The following is a description of a gene set: Any complex of actin, myosin, and accessory proteins. Mouse Gene Set: GOCC_ACTOMYOSIN studied in species Mus musculus, and this is the list of marker genes: Rai14, Xirp2, Pdlim5, Myl9, Micall2, Coro2b, Dixdc1, Ptk2, Sorbs1, Myh14, Kat2b, Fscn1 (NCBI Gene Id 14086), Ablim1, Sh2b2, Myh11, Ptpn11, Pxn, Gas2l2, Fblim1, Gas2l1, Ablim3, Prickle4, Limch1, Anxa2, Mst1r, Nebl, Shroom4, Nox4, Fhl3, Mlph, Pgm5, Cttnbp2nl, Zyx, Mylk, Pdlim2, Myh10, Daam1, Myh6, Fhod1, Actn1, Tlnrd1, Ror1, Dst, Synpo, Stx1a, Pdlim1, Cdc42bpb, Ppp1r12b, Trip6, Fermt2, Pdlim4, Vangl2, Synpo2, Mprip, Afap1l1, Cnn2, Myl12a, Palld, Septin5, Asb2, Coro1b (NCBI Gene Id 23789), Fam107a, Actb, Lurap1 (leucine rich adaptor protein 1), Tmsb15l, Ppp1r12c, Myh9, Flnb, Enah, Tek, Acta1, Lcp1, Actn4, Pdlim3, Acta2, Cdc42bpa, Vcl (NCBI Gene Id 268722), Septin9, Dctn4, Tpm3, Cyba, Ldb3, Tpm1, Prkcz, Spef1, Myo18a, Septin11, Pdcd6ip, Afap1, Hdac4, Xirp1, Myl12b, Myo5a, Evl, Bloc1s6, Dlc1, Klhl2, Sipa1l3, Myh7, Lima1, Ilk, Pstpip1, Luzp1, Septin7, Tmsb15b2, Pdlim7, Ppp1r12a, Gas2, Lpp, Amot, Tpm4